Given this list of marker genes MIR200C, LEAP2, PAK6, ERICH4, RNU6-1093P (NCBI Gene Id 106481524), PRODH, FERMT1, SCAT8, LCT, FOLH1, MIR4307HG, ABCG5, MME-AS1, CLIC6, RBBP8NL, SIGLEC10-AS1 (NCBI Gene Id 100129083), ITPKA, AICDA, MT1E, LINC01794, LRRC19, WIPF3, LIPH, BICDL3P, UPK3A, ALDH1L1, TRIM15 (NCBI Gene Id 91943), MOGAT3, LAMB3, SMLR1, SLC5A1, XPNPEP2, SULT1B1, MTTP, C8G, CPS1, GDPD2, LINC01610, DEGS2, TUBAL3, AGR3, HSD17B2 (hydroxysteroid 17-beta dehydrogenase 2), CYP2C9, CUBN, AIDAP2, IYD, TMC5 (NCBI Gene Id 79838), SMIM24, GCHFR, MUC13, SLC13A1, ANXA4, PIGR, RHPN2, VIPR1, C2orf72, CYP3A5, CA7, PRKAG2-AS2, ENPP7, LINC01525, MIR194-2HG, SH3RF2, CALR4P, DLX4, SLC44A4, INAVA, CREB3L3, CFTR, PRSS3, HHLA2, LINC00479, GPX2, GRHL2, CYP2W1, GJB1, SLC9A3, PKP3, TM4SF20, FABP1, UBE2V2P1, LINC02499, AMN, SLC28A1, TREH, CDX1, SULT2A1, AIRE, UNC5CL, RNU1-70P, SPANXN3, SMAD3-DT, SLC34A3, APOA1, ARL14, MFSD6L, OR7E14P, ZDHHC23, GDA, ENSG00000267709, XACT, PLEKHS1, AFP, SPACA3, LINC00501, ALDOB, LINC01697, ACSL5, ELF3, FBXO2, REEP6, FOXD2-AS1, FABP2, MIR200B, DGAT1, ADGRG7, MUC17, NAT2, TRIM31, PRR15, CASC16, FGA, MMEL1-AS1, DEFB1, APOC3, ACE2, MASP1, CCL25, ELMO3, APOB, RBP2, CYP2U1-AS1, GUCA2B, TMPRSS2, TMEM92, LBX2-AS1, AFM, PRAP1, FMO1, MGAM2, S100A14, AVP, SLC2A2, PPP1R3B-DT, DMBT1, EEF1B2P3, GRTP1, APOA2, AGMAT, FGF23, GSTA1, MEP1A, RN7SKP22, SLC39A4, TMT1B, BICDL2, SLC51A, SLC6A20, PCK2, SEMA4G, ATP10B, TRPV6, HDHD3, SLC5A12, PIGZ, RBKS, HMGN1P20, TMEM139, SLC28A2, CELP, STRIT1, GLTPD2, MOGAT2, SNORD55, UGT2A3, LINC00330, ZG16 (zymogen granule protein 16), GRHL2-DT (NCBI Gene Id 107986962), RBP4, GUCA2A, SLC1A1, MUC2, ADORA2A-AS1, SLC19A3, LINC01594 (NCBI Gene Id 102724774), EXOC3L4, SULT1C2, SCTR-AS1, CYP2B7P, GSTA2, CIMAP2, CEACAM18, ABCC2, CHP2, PRSS8, AADAC (NCBI Gene Id 13), SFRP5, ANPEP, CDS1, XDH, CLDN2, LGALS3, THRB-IT1, ADH1C, EREG, SPTLC3, PBLD, C6, CES2, TINAG, NAGS, ANKRD40CL, TSPAN8, CLDN6 (NCBI Gene Id 9074), GPD1, C5orf52, FADS6, SLC51B, CLCA1, TFF1, CIDEC, AADACP1, ESRP2, BTNL3, TJP3, RAD17P1, BCAR3-AS1, APOA4, LINC01214, CCDC198, SULT1E1, F2RL1, C11orf86, UGT3A1, C15orf62 (chromosome 15 open reading frame 62), LINC00955, TMEM52, MAMDC4, MYOM3-AS1, EPS15-AS1, PLA2G12B, CYP2C18, CRB3, MT1G, TMEM207, TPSG1 (NCBI Gene Id 25823), MT1H, GLYCTK, ASAH2, SERPINA4, MAOB, UGT2B17, TERT, HNF4A-AS1, NR1I2, SULT1C5P, AGT, HKDC1, ST6GALNAC1, TMIGD1 (NCBI Gene Id 388364), LGR5, SLC16A10, KRT20, KHK, SLC17A4, FAM83B, TMEM45B, ANKRD20A5P, PCK1, TMEM253, SI, GCNT4, EGFR-AS1, SLC6A19 (NCBI Gene Id 8062), ALPI, GIPC2, SLC5A9, CYP2C19, RASEF, here is a description of the gene set: Human Gene Set: DESCARTES_FETAL_INTESTINE_INTESTINAL_EPITHELIAL_CELLS The gene expression program underlying the specification of human cell types is of fundamental interest. The study authors generated human cell atlases of gene expression and chromatin accessibility in fetal tissues. For gene expression, the study authors applied three-level combinatorial indexing to >110 samples representing 15 organs, ultimately profiling ~4 million single cells. The study authors leveraged the literature and other atlases to identify and annotate hundreds of cell types and subtypes, both within and across tissues. Our analyses focused on organ-specific specializations of broadly distributed cell types (such as blood, endothelial, and epithelial), sites of fetal erythropoiesis (which notably included the adrenal gland), and integration with mouse developmental atlases (such as conserved specification of blood cells). These data represent a rich resource for the exploration of in vivo human gene expression in diverse tissues and cell types. species: Homo sapiens from publication Cao J, O'Day DR, Pliner HA, Kingsley PD, Deng M, Daza RM, Zager MA, Aldinger KA, Blecher-Gonen R, Zhang F, Spielmann M, Palis J, Doherty D, Steemers FJ, Glass IA, Trapnell C, Shendure J (PMID 33184181) Marker genes curated from the annotated cluster as represented in the Descartes Human Gene Expression During Development database.